The following is a description of a gene set: The cytokine scatter factor (SF) (hepatocyte growth factor) transduces various biologic actions, including cell motility, invasion, angiogenesis and apoptosis inhibition. The latter is relevant to understanding the role of SF in promoting tumor cell survival in different contexts, for example, detachment from basement membrane, growth in metastatic sites and responses to chemo- and radiotherapy. Previously, we showed that SF protects cells against apoptosis owing to DNA damage, by a mechanism involving phosphoinositol-3-kinase/c-Akt signaling. Here, we used DNA microarray assays to identify c-Akt-regulated genes that might contribute to cell protection. DU-145 human prostate cancer cells were transfected+/-a dominant-negative mutant Akt, treated+/-SF and analysed for gene expression using Affymetrix arrays. These studies identified SF-regulated genes for which induction was c-Akt-dependent vs -independent. Selected microarray findings were confirmed by semiquantitative and quantitative reverse transcription-polymerase chain reaction. We tested the contribution of four SF-inducible/c-Akt-dependent genes (AMPD3, EPHB2, MX1 and WNT4) to protection against adriamycin (a DNA topoisomerase IIalpha inhibitor) using RNA interference. Knockdown of each gene except EPHB2 caused a small but significant reduction in the SF cell protection. The lack of effect of EPHB2 knockdown may be due to the fact that DU-145 cells contain a single-mutant EPHB2 allele. A combination of three small interfering RNAs blocked most of the protection by SF in both DU-145 and T47D cells. These findings identify novel c-Akt-regulated genes, some of which contribute to SF-mediated cytoprotection. Genes changed similarly in DU-145 cells (prostate cancer) in the absence and presence of a dominant negative form of AKT1 upon exposure to HGF for 6 h. from publication Xu J, Gao M, Fan S, Meng Q, Goldberg ID, Abounader R, Ressom H, Laterra JJ, Rosen EM (PMID 17099727) species: Homo sapiens Human Gene Set: XU_HGF_SIGNALING_NOT_VIA_AKT1_6HR, and this is the list of marker genes: PLAU, CD44, PRSS22, PFKFB3, TNFRSF10B, ERCC1, HPCAL1, IL6ST, NAV3, SMTN, ANGPTL4, JUN, EHD1, SAT1, DNMBP, UPP1, ASAP2, HBEGF, MAMLD1, PXN, SMURF2, LSS, PLAUR, LSR, PHLDA2